The following is a description of a gene set: This event has been computationally inferred from an event that has been demonstrated in another species.<p>The inference is based on the homology mapping from PANTHER. Briefly, reactions for which all involved PhysicalEntities (in input, output and catalyst) have a mapped orthologue/paralogue (for complexes at least 75% of components must have a mapping) are inferred to the other species. part of: L1CAM interactions electronically inferred by orthology from the curated human pathway Reactome Pathway: Interaction between L1 and Ankyrins species: Mus musculus, and this is the list of marker genes: Sptbn4 (NCBI Gene Id 80297), Ank1, Sptbn2